The following is a description of a gene set: species: Mus musculus Mouse Gene Set: REACTOME_DNA_DAMAGE_BYPASS DNA Damage Bypass, and this is the list of marker genes: Ddb1, Rchy1, Cul4b, Rfc3, Rfc2, Wdr48, Pole2, Uba52rt, Nploc4, Rad18, Poli, Trim25, Rev1, Polk, Usp10, Usp43, Isg15, Ubc, Uba52, Uba7, Pole, Polh, Mad2l2, Sprtn, Usp1, Rpa1, Pole3, Rpa2, Ubb (NCBI Gene Id 22187), Pold1, Vcp, Pold4, Pole4, Ufd1, Cul4a, Pclaf, Rpa3, Rps27a, Dtl (NCBI Gene Id 76843), Rbx1, Pold2, Ube2l6, Rfc5, Rfc4, Rfc1, Pold3, Ube2b, Rev3l, Pcna